Given this list of marker genes Mars1, Erbb2, Rasl11a, Sirt7, Mybbp1a, Baz1b, Smarca5, Ddx21 (DExD box helicase 21), Pih1d1, Dhx33, Dek, Mtor, Ippk, Atf4, Pwp1, Myo1c, Eif2ak3, Smarca4, Smarcb1, Ddx11, Ppp1r15a, Ubtf, Utp15, Bnc1, Heatr1, Lyar, Ubtfl1, Sf3b1, Nol11, Ncl, Wdr43, Actr6, Ercc6, Phf8, Wdr75, here is a description of the gene set: species: Mus musculus Any process that activates or increases the frequency, rate or extent of transcription mediated by RNA polymerase I. Mouse Gene Set: GOBP_POSITIVE_REGULATION_OF_TRANSCRIPTION_BY_RNA_POLYMERASE_I